The following is a description of a gene set: part of: Platelet activation, signaling and aggregation Reactome Pathway: GPVI-mediated activation cascade The GPVI receptor is a complex of the GPVI protein with Fc epsilon R1 gamma (FcR). The Src family kinases Fyn and Lyn constitutively associate with the GPVI-FcR complex in platelets and initiate platelet activation through phosphorylation of the immunoreceptor tyrosine-based activation motif (ITAM) in the FcR gamma chain, leading to binding and activation of the tyrosine kinase Syk. Downstream of Syk, a series of adapter molecules and effectors lead to platelet activation. <br><br>The GPVI receptor signaling cascade is similar to that of T- and B-cell immune receptors, involving the formation of a signalosome composed of adapter and effector proteins. At the core of the T-cell receptor signalosome is the transmembrane adapter LAT and two cytosolic adapters SLP-76 and Gads. While LAT is essential for signalling to PLCgamma1 downstream of the T-cell receptor, the absence of LAT in platelets only impairs the activation of PLCgamma2, the response to collagen and GPVI receptor ligands remains sufficient to elicit a full aggregation response. In contrast, GPVI signalling is almost entirely abolished in the absence of SLP-76. studied in species Homo sapiens, and this is the list of marker genes: FYN, PIK3CB, PDPN, RHOB, VAV1, PIK3R5, PRKCZ, PIK3R6, MPIG6B, PIK3R3, PTPN11, PIK3CG, CLEC1B, LCP2, RAC1, LAT, CDC42, VAV3, VAV2, PLCG2, PTPN6, FCER1G (Fc epsilon receptor Ig), LYN, RHOA, PIK3CA, LCK, PIK3R1 (phosphoinositide-3-kinase regulatory subunit 1), GP6, RAC2, COL1A1, COL1A2 (NCBI Gene Id 1278), RHOG, PDPK1, SYK, PIK3R2